Given this list of marker genes HDAC1, GNAS (GNAS complex locus), HDAC2, CTNNB1, EDA, DKK4, here is a description of the gene set: Human Gene Set: GOBP_HAIR_FOLLICLE_PLACODE_FORMATION The developmental process in which a hair placode forms. An hair follicle placode is a thickening of the ectoderm that will give rise to the hair follicle bud. studied in species Homo sapiens